Given this list of marker genes NPY2R, INS, NAPEPLD, NPSR1, RETN, UCN, NMU, TTC21B, here is a description of the gene set: Human Gene Set: GOBP_NEGATIVE_REGULATION_OF_FEEDING_BEHAVIOR Any process that stops, prevents or reduces the frequency, rate or extent of feeding behavior. studied in species Homo sapiens